The following is a description of a gene set: species: Homo sapiens Induction of Cell-Cell Fusion Human Gene Set: REACTOME_INDUCTION_OF_CELL_CELL_FUSION, and this is the list of marker genes: ANO6, FURIN, ACE2, ANO3, TMPRSS2, ANO2, ANO10, ANO4, ANO1, ANO5, ANO7, ANO9 (anoctamin 9), ANO8